Given this list of marker genes Pla2g4d, Pla2g1b, Pla2g5, Plbd1, Pla2g2a, Pla2g12a, Mboat7, Pla2g4f, Pla2g2f (NCBI Gene Id 26971), Pla2r1, Pla2g2e, Pla2g2d, here is a description of the gene set: This event has been computationally inferred from an event that has been demonstrated in another species.<p>The inference is based on the homology mapping from PANTHER. Briefly, reactions for which all involved PhysicalEntities (in input, output and catalyst) have a mapped orthologue/paralogue (for complexes at least 75% of components must have a mapping) are inferred to the other species. Reactome Pathway: Acyl chain remodelling of PI studied in species Mus musculus part of: Glycerophospholipid biosynthesis electronically inferred by orthology from the curated human pathway